Given this list of marker genes GP1BB, CTNS, SDHA, PRKG2, NPAP1, MYO9A, MAGEL2, SLCO2A1, COMT, SERPINH1, CDC45, BPNT2, SRD5A3, C19orf12, CHST3, PRKACB, CLDN16, FN1, IARS2, IFT57, EP300, USP9X, ZPR1, ATP7A, DPM1, TAF4, PRMT7, UGP2, KIF22, CYP2R1, DHX16, MCTP2, LMNA, HS2ST1, SLC25A46, MIA3, CBFB, UFC1, RREB1, DPAGT1, PRKAR1A, TRIP11, MAPK8IP3, NDUFAF6, CDC6, TTI1, CFL2 (cofilin 2), FKBP10, MAN2B1, TPM2, SPTBN1, TGFB1, SCYL2 (NCBI Gene Id 55681), MEGF8, KAT6A (NCBI Gene Id 7994), GLB1, STAT4, STX5, NLRP3, ORC1 (NCBI Gene Id 4998), BHLHA9, UFD1, MYL2, FDFT1, CNTNAP1, ENPP1, HERC2, ARSB, EMD, HS6ST1, BICD2, POLRMT, HACD1, ZBTB20, SEC24C, RPGRIP1L, BGN, CHRNG, IHH, LMBR1 (NCBI Gene Id 85501), VDR, PRG4, DDR2, RPL10, DNMT3A, DNAJC30, HBB, MAP3K20, GTF2I, PDE4D, JMJD1C (jumonji domain containing 1C), CBS, METTL27, SF3B2, CRELD1, EFL1, SIK3, HPGD, LTBP1, SPART, COL10A1, IDH1, TPM3, TGDS, SKI, EXT1, ANAPC1, CLCN7, SMAD2, EVC, NEB, PITX1, OCRL, TELO2, CYP19A1, XYLT1, GTF2IRD2, FBN1, RAB23, DYNC2LI1, ERI1, FILIP1, ZSWIM6, NKX3-2, CDT1, CLIP2, ARFGEF2 (NCBI Gene Id 10564), PWRN1, AIFM1, PIK3R2, PIGY, CHRNB1, KIF7, NOTCH2, SOX9, COL9A2, FBN2, CD247, RPL13, PMP22, FHL1, PIGA, PWAR1, LONP1, WDR62, FLNB, GNPTG, MKRN3, PRKACA, CTCF, GDF5 (growth differentiation factor 5), DMP1, SYT2, PUS3 (NCBI Gene Id 83480), ALG2, UBA1, GMNN, BMP4, IFIH1, COL12A1, ZEB2, RTTN, EXT2, ZNF699, COMP, HSPG2, BUD23, MAP2K2, NEPRO, TBX4, PKDCC, PIEZO2, PSTPIP1, ORC6, BAG3, CTC1, ATP6V1E1, COX11, SDHB, MYL11, B3GALT6, DONSON, ARF1, ERGIC1, MYH3, SMAD3, SCARF2, IDH2, TBC1D7, COL6A3, STX1A, SLC26A2, MAB21L2, SHOX, FGFR3, COL1A2, ARID1B, TNFSF11, AHDC1, PSAT1, PLAAT3, HYAL1, COL25A1, CHST11, POLR3A, ACAN, NFATC2, TRIM2, SNAP25, UFSP2, RBM8A, UBR7, MYL1, KLHL41, COG8, SHH, RMRP, B3GAT3, GFPT1, ERLIN2, DYM, PTPN22, NAA60, TBL2, SELENON, NEDD4L, LMBRD2, IL2RB, MAP1B (microtubule associated protein 1B), ACTA1, TRPV4, TBX1, SVIL, TONSL, PLOD2, NF1, MATN3, BCOR, GAN, ERLIN1, COL6A2, YY1, ANKLE2, VPS37D, ERCC6, RNU4ATAC (RNA, U4atac small nuclear), GNB2, NCF1, TRPS1, SLC39A8, ADAMTS15, GNPTAB, GJB6, MTX2, COL9A3, CAMK2A, IPO8, COL5A2, ATRX, LMX1B, LIMK1, VPS13B, GMPPB, LGI4, SLC10A7, SNORD116-1, PHLDB1 (NCBI Gene Id 23187), COL5A1, CREBBP, EBP, GUSB, RFC2, IL2RA, RYR1, EXOC6B, SDHD, FLNA, LMOD3 (NCBI Gene Id 56203), CYP3A4, ESCO2, SNORD115-1, ALG14, CSGALNACT1, UNC80, IDUA, HEATR3 (HEAT repeat containing 3), KY, SDHAF1, TMTC3, PTDSS1, WNT7A, SLC18A3, PTH1R, ERCC1, AEBP1, NSD1, FZD2, JAG2, ADNP (NCBI Gene Id 256440), FKBP6, MPZ, PHEX, DMD, RUNX2, BRF1, COG5, KAT6B, TMEM270, BRAF, IFT172, PTPN2, SFRP4 (NCBI Gene Id 6424), BAZ1B, WNK3, GJB2, CANT1, EIF2AK3, RECQL4, MMP13, NALCN, EIF4H, RAB33B, PLOD1, CENPT, COL2A1, EVC2, RAD21, MMP9, MEGF10, LBR, PI4KA, TUBB3, RSPRY1, TFE3, ORC4, PIK3CA, ANKRD55, COL9A1, COL11A1, TRAPPC2, ITGA7, GNPAT, PEPD, ERMARD, TCTN3, P4HTM, GTF2IRD1, CYP27B1, ARSK, NT5C2, GALNS (galactosamine (N-acetyl)-6-sulfatase), DDRGK1, GLI3, COL1A1, HIRA, LIFR, GLI1, SCN4A, H3-3B, ARVCF, COL6A1, ELN, CCN6, KRAS, STXBP1, MAP2K1, CPT2, here is a description of the gene set: A structural abnormality of the knee joint or surrounding structures. Abnormal knee morphology species: Homo sapiens Human Gene Set: HP_ABNORMAL_KNEE_MORPHOLOGY